Given this list of marker genes E2F7, SENP2 (SUMO specific peptidase 2), ZPR1, FBXO5, E2F8, here is a description of the gene set: Regulated re-replication of DNA within a single cell cycle, resulting in an increased cell ploidy. An example of this process occurs in the synthesis of Drosophila salivary gland cell polytene chromosomes. species: Homo sapiens Human Gene Set: GOBP_DNA_ENDOREDUPLICATION